Given this list of marker genes POU2AF2, POU2AF1, NFKBIZ, POU2AF3, AR, here is a description of the gene set: Binding to a POU domain of a protein. The POU domain is a bipartite DNA binding domain composed of two subunits separated by a non-conserved region of 15-55 amino acids; it is found in several eukaryotic transcription factors. studied in species Homo sapiens Human Gene Set: GOMF_POU_DOMAIN_BINDING